The following is a description of a gene set: Human Gene Set: GSE34515_CD16_POS_MONOCYTE_VS_DC_UP In this study gene expression of human blood classical monocytes (CD14++CD16-), CD16 positive monocytes (consisting of non-classical CD14+16++ and intermediate CD14++CD16+ monocytes) and CD1c+ CD19- dendritic cells from healthy subjects were investigated. species: Homo sapiens from publication Frankenberger M, Hofer TP, Marei A, Dayyani F, Schewe S, Strasser C, Aldraihim A, Stanzel F, Lang R, Hoffmann R, Prazeres da Costa O, Buch T, Ziegler-Heitbrock L (PMID 22531920) Genes up-regulated in CD16+ monocytes versus dendritic cells., and this is the list of marker genes: ZC3H7B, TOPBP1, FYN, NRBF2, CDK5R1, TP53BP2, YIPF5, DHRS3, MAP4K5, FRMD6, LONRF1, ITM2B (NCBI Gene Id 9445), KCNK6, EED, SEC24D, BRD9, CD5, TP53BP1, MCM9, MPZL1, PPIE, LYSMD3, ACTG1, RIF1, INTS6L, CDKN2B, CPM, SAMTOR, BMPR2, ZC3H15, CRY1, HSP90AA1, ITGAL, NFKBIA, PLSCR1, STYX, TNFAIP8, YME1L1, ANXA11, DYNLT2B, ACVRL1, ZMYND11, EXO1, AKAP7, SFR1, PHTF2, SELENOF, IDS, PER1, RRAD, MIER1, SPDYA, ABL2, FYTTD1, NCMAP, CHAMP1, IMPACT, NRIP1, PCLAF, DSCAM, STK17B, CSTF2T, RPA1, KANSL1L, CHRNB1, FDX1, KHDRBS1, ETAA1, NUP155, FANCF, ABRACL, JARID2, FOXA1 (NCBI Gene Id 3169), AKAP8L, MYO5A, DLG1, CCNC, SULF2, MARCHF6, TMEM30A, TMPO (thymopoietin), PGLYRP1 (NCBI Gene Id 8993), FAM110A, ATL2, TTC14 (tetratricopeptide repeat domain 14), MMS22L, MGAT5, BAIAP3, SERP1, BUB1B, CCDC6, KDM7A, IL15, SACM1L, EBF1, KPNA3, ELOVL4, ITPRIPL2, CMPK1, FLNB, CHIC2, RNF103, PPP1CB, ZBTB38, GSK3B, NAB1, EFHC2, ERCC6, SLC22A2, MYO1E, TAF5L, ZNF800, SLC35E2B, B9D2, SDR39U1, TRA2B (NCBI Gene Id 6434), EIF2AK4, UPF3B, GRAMD1C, RIN2, FGL2, JUNB, AGFG1 (NCBI Gene Id 3267), HIVEP3, GGT7, BAZ2B, STAU1, CD27, NKG7, DDX17, TWF1, SPOCK2 (SPARC (osteonectin), cwcv and kazal like domains proteoglycan 2), WDR6, BID, VIL1, PFN2, CASP8AP2, PWP1, KLF6, TMEM161B, TNKS2, RCL1, DYM, ARMCX4, SNX4, ARID5A, TNIP1, HSPA5, LXN, RAB3GAP2, PPIG, LMBRD1, ALMS1, ZNF512B (NCBI Gene Id 57473), SAR1A, ZMIZ1 (zinc finger MIZ-type containing 1), VEZF1, HNRNPDL, ZBTB32, FUS, NDEL1, ACTR2, RPAP3, TMEM165, FMNL3, TEX2, KIF1C, SH3GL3, PABPC1, LMNA, PRKG1, IGF2R, CSDE1, CCDC88C, PRICKLE2 (prickle planar cell polarity protein 2), EBI3, FPGT, CEP76 (NCBI Gene Id 79959), UBA5, ST6GALNAC2, MSL3, MKNK2, PEX2, CMTM7, CXCL11, HIF1A, EPC2, ABHD4, DIPK2A, BDH2, DDX28, SLC25A19, MOB4, PON2, FNBP1, SERINC3, LPIN2, PAK1IP1, XPR1, NR3C2